The following is a description of a gene set: Mouse Gene Set: GOMF_MUTSALPHA_COMPLEX_BINDING Binding to a MutSalpha mismatch repair complex. species: Mus musculus, and this is the list of marker genes: Trex1, Pms2, Mlh1 (NCBI Gene Id 68687), Atr, Mcm8, Mcm9 (minichromosome maintenance 9 homologous recombination repair factor), Mutyh